Given this list of marker genes Smarcal1, Slc7a8, Nap1l1, Map7, Lipo1, Arpp21, Mrtfb, Mrs2, Mprip, Dusp10, Snx16, Fat1, Ncoa1, Myo19, Hsf2, Amy2a3, Rock1, Lnpk, Clint1, Dars2, Syt9, Ston2, Gmps, Tlcd5, Lsm14b, Snai3, Srsf12, Lhfpl2 (lipoma HMGIC fusion partner-like 2), Fam168a, Crim1, Gm8978, Ugcg (UDP-glucose ceramide glucosyltransferase), Intu, Crem, Onecut2, Trp53inp2, Grem1, Slit2, Rictor, Ap3s1, Rac1, Slc4a8, Amy2a4, Zfp454, Nlk, Pkia (protein kinase inhibitor, alpha), Ncor2, D2hgdh, Sdc1, B4galt4, Tram1, Klf12, Trappc9, Cxxc5, Fam107b, Numbl, Lysmd2, Tmem54, Zfp462, Gdap2, Amy2a2, Dock9, Zbtb20, Lrrc28, Pls3, Mmp1a, Fgf12, Rnf6, Scml2, Pwwp3b, Pla2r1, Tsg101, Rufy3, Phf20l1, Arl6ip5, Syt4, Galnt7, Plch2, Adcy9, Psmf1, Cdh8, Stim1 (stromal interaction molecule 1), Cntln, Spdl1, Itgal, Nid2, here is a description of the gene set: species: Mus musculus Mouse Gene Set: MIR_182_3P Genes predicted to be targets of miRBase v22 microRNA mmu_miR_182_3p in miRDB v6.0 with MirTarget v4 prediction scores > 80 (high confidence targets). from publication Chen Y, Wang X (PMID 31504780)